The following is a description of a gene set: The process whose specific outcome is the progression of the hindbrain over time, from its formation to the mature structure. The hindbrain is the posterior of the three primary divisions of the developing chordate brain, or the corresponding part of the adult brain (in vertebrates, includes the cerebellum, pons, and medulla oblongata and controls the autonomic functions and equilibrium). Mouse Gene Set: GOBP_HINDBRAIN_DEVELOPMENT studied in species Mus musculus, and this is the list of marker genes: Herc1, Wnt7a, Pianp, Kdm2b, Gli2, Kif14, Hoxb2, Flna, Hoxb1, Pdss2, Serpine2, Wls, Clp1, Aldh1a2, Ogdh, Kcne1, Cacna1a, Igf1, Pou4f1, Pfdn1, Lmx1b (NCBI Gene Id 16917), Bcl2, Myh10, Agtr2, Foxc1, Fgf2, Arhgap32, Atf2, Gba1, Mtpn, Whrn, Sema4c, Atrn, Fcgr2b, Hspa5, Comt, Ascl1, Cdk5, Dixdc1, Hnf1b, Ncoa1, Slc25a46 (solute carrier family 25, member 46), Aars1, Atic, Psen1, Ophn1, Egf, Abl2, Atxn2, Lpar1, Ctnna2, Wnt1, Neurod2, Phox2a, Nfix, Fktn, Pcnt, Nlgn4l, Gpr37l1, Dlc1, Nog, Ncstn, Gabrb3, Dll1, Sez6, Cbs, Hoxa2, Nfib, Nrxn1, Mafb, Cplane1, Klhl1, Rora, Prkg1, Nr2c2, Ldb1, Psmg1, Cntnap2, Rnf7, Naglu, Gata2, Trnp1, Lef1, C5ar1, Skor2, Grin1, Cul5, Rere, Ulk1, Ttll1, Atp7a (NCBI Gene Id 51824), Hoxb3, Atg7, Sstr3, Ttbk2, Lrp6, Grid2, Otx1, L1cam, Zfp423 (NCBI Gene Id 94187), Mecp2, Abl1, Dab1, Nhlh2, Gart, Neurog3, Nanos1, Prox1, Coq8b, Atf5, Tbr1, Myo16, Mdk, Hes3, Hap1, Otx2, Cdk5r2, Crk, Ephb1, Gas1, Atp1b2 (NCBI Gene Id 11932), Gsx2, B4galt2, Gdf10, Cntn1, Lhx5, Bmp5, Zfp365, Hoxa1, Cdk5r1, Ctnnb1, Ezh2, Crkl, Pantr2, Sez6l, Gnpat, Ptpn11, Samd4b, Zbtb18, Igf1r, Rbfox2, Foxp2, Ptf1a, Cbln1, Smo, Sez6l2, Cd3e, Itgb1, Tuba1a, Usp9x, mt-Co1, Foxa2, mt-Nd4, Gli1, Egr2, Sdf4, Smarca4, Shh, Ttc21b, Agtpbp1, Ptprs, Sptbn2, Cep290, En1, Slc4a7, Pax6, Abat, Lhx1, Kcnc1, Faim2, Socs7, Hes1, Gbx2, En2, Map2k1, Hspa8 (NCBI Gene Id 69197), Neurod1, Sstr1, Kat2a, Psap, Fzd4, Rpgrip1l, Phox2b, Sec24b, Atp2b2, Glud1, Smad1, Gpx4, Trp53, Hnrnpd, Ephb2, Slc6a4, Lmx1a, Plxna2, Smad9, Scrib, Bmp7, Arl13b, Uqcrq, Sstr2, Cend1, Arcn1, Kndc1